The following is a description of a gene set: studied in species Homo sapiens Reactome Pathway: SARS-CoV-2 Infection The inference process created SARS-CoV-2 events corresponding to each event in the SARS-CoV-1 pathway and populated those events with SARS-CoV-2 protein-containing physical entities based on orthology to SARS-CoV-1 proteins (https://reactome.org/documentation/inferred-events). Within the endocytic vesicle, host proteases mediate cleavage of S protein into S1 and S2 fragments, leading to S2‑mediated fusion of the viral and host endosome membranes and release of the viral capsid into the host cell cytosol. The capsid is uncoated to free the viral genomic RNA, whose cap‑dependent translation produces polyprotein pp1a and, by means of a 1‑base frameshift, polyprotein pp1ab. Autoproteolytic cleavage of pp1a and pp1ab generates 15 or 16 nonstructural proteins (nsps) with various functions. Importantly, the RNA dependent RNA polymerase (RdRP) activity is encoded in nsp12. Nsp3, 4, and 6 induce rearrangement of the cellular endoplasmic reticulum membrane to form cytosolic double membrane vesicles (DMVs) where the viral replication transcription complex is assembled and anchored. With viral genomic RNA as a template, viral replicase‑transcriptase synthesizes a full length negative sense antigenome, which in turn serves as a template for the synthesis of new genomic RNA. The replicase‑transcriptase can also switch template during discontinuous transcription of the genome at transcription regulated sequences to produce a nested set of negative‑sense subgenomic (sg) RNAs, which are used as templates for the synthesis of positive‑sense sgRNAs that are translated to generate viral proteins. Finally, viral particle assembly occurs in the ER Golgi intermediate compartment (ERGIC). part of: SARS-CoV Infections, and this is the list of marker genes: NLRP12, GANAB, 6, MGAT4B, SNRPG, GALNT1, PALS1 (NCBI Gene Id 64398), SEH1L, IRF7, 7SL RNA (ENSG00000222639), VPS41, NUP153, NUP54, TLR7, SNRPF, MASP1, TRIM4, STAT2, TYK2, ANO1, HLA-E, SAR1B, SDC4, HSPG2, YWHAB, IFNB1, SEC23A, HLA-B, ST6GALNAC3, RPS4X, ST3GAL1, IFNA14, 9b, TMEM258, RPS2, GPC5, PARP8, TMPRSS2, PDPK1, NUP37, 7a, EDEM2, SDC1, SARS coronavirus, complete genome, RAE1, ZDHHC9, TAB3, G3BP2, ST3GAL3, RPS3, PIK3R4, GSK3B, TUSC3, NUP107, RPS20, TRAF3, VPS39, IL17RA, DDX20, CSNK1A1, PATJ, DDOST, NUP155, ANO2, MGAT5, E, RPS8, VCP, RPS29, NUP35, GPC2, IFNA8, SFTPD, IFNA21, OSTC, CHUK, IL17F, SDC3, UBC, SNRPB, NUP43, RPS28 (NCBI Gene Id 6234), NUP50, GPC4, SNRPE (small nuclear ribonucleoprotein polypeptide E), ANO10, RPN1, VHL (von Hippel-Lindau tumor suppressor), ZDHHC3, UVRAG, ANO7, NUP85 (NCBI Gene Id 83705), UBA52, ANO3, HLA-F, MOGS, M, CREBBP, NRP1, IFNA1, SEC24C, B2M, RPS15, RPS12, TRIM25, RB1, RPS7, ANO6, RPS27L, GEMIN5, SEC13, PIK3C3, CHMP2B (charged multivesicular body protein 2B), CHMP4C, HLA-A, RPS25, GEMIN7, PARP9, YWHAE, TPR, PTPN11, SEC24A (NCBI Gene Id 10802), MAGT1, AAAS, LARP1, MGAT4C, NUP133, IL17A, PARP14, 18S rRNA, PARP6, ANO5, ZDHHC2, IFNA7, MGAT2, PARP16, ACE2, YWHAH, PRKCSH, CTSL, SNRPD2, NUP98, IFNA5, pp1a, HLA-H, TLR8, IRAK1, NUP160, RANBP2, UBE2V1, CHMP7, RPS19, ANO8, RPS6, ANO4, UBE2N, RPS18, TAB1, JAK1, CHMP6, SRPK1, VPS45, RPS4Y2, UBE2I, IFNA2, rep, FURIN, IFNA17, TLR2 (NCBI Gene Id 7097), IFNA10, KPNA2, SMN1, NUP62, RPS14, 3a, TLR1, SNRPD3, STING1, CAV1, ZDHHC20, RPS3A, POM121 (POM121 transmembrane nucleoporin), FAU, TKFC, HSP90AA1, NUP205, CHMP4A (charged multivesicular body protein 4A), AKT1, AKT3, TAB2, STT3B, SEC24D, ZCRB1, RPS27, RPS4Y1, GPC3, MBL2, RPN2, IFNA6, MAVS, NLRP3, HAVCR1, RPS17, CHMP3, FUT8, RPS13, RPS21, GJA1, GOLGA7, ISCU, ZDHHC11, IFNAR1, NUP210, GSK3A, IRF3, STT3A, YWHAG, IKBKE, RPS24, VPS33B, HSP90AB1, NUP58, RPS15A (NCBI Gene Id 6210), RPS11, OST4, BECN1, HLA-G, GPC1, ZDHHC8, CHMP2A, CANX, IKBKG, YWHAQ, UBB, NUP214, SRPK2, IKBKB, NUP42, ST6GALNAC4, VPS33A, RPS27A, PTPN6, SDC2, MAN1B1, RPS16, NOD2, ZDHHC5, ATG14, GEMIN8, DAD1 (defender against cell death 1), RPS26, GEMIN2, TUFM, AKT2 (AKT serine/threonine kinase 2), IL17RC, RIGI, MAN2A1, ST3GAL4, CHMP4B, SIKE1, NUP93, RPS10, NOD1, VPS16, IFIH1, STAT1, DDX5, RPSA, TBK1, NDC1, ANO9, GEMIN6, ST6GAL1, SEC24B, VPS18, ST6GALNAC2, RPS5, IRAK2, TRAF6, CRB3, IFNA4, HLA-C, GPC6, RPS23, RIPK2, SFN, YWHAZ, 8, S, POM121C (NCBI Gene Id 442581), N, NUP88, TOMM70, MGAT1 (NCBI Gene Id 4245), G3BP1, SUMO1, SNRPD1, PRMT1, TJP1, AGRN, ST3GAL2, RNF135 (ring finger protein 135), PARP4, GEMIN4, MAP1LC3B, NUP188, VPS11, IFNAR2, RPS9, ISG15, MASP2, MAP3K7, IFNA16, MGAT4A, 7SL RNA (ENSG00000222619), PARP10, CNBP